The following is a description of a gene set: A metabolic process that generates a pool of NADPH by the reduction of NADP+. species: Mus musculus Mouse Gene Set: GOBP_NADPH_REGENERATION, and this is the list of marker genes: Trp53, H6pd, G6pd2, Tkt, G6pdx, Taldo1, Rbks, Pgls, Aldh1l2, Idh1, Mtor, Prps2, Mlst8, Acacb, Aldh1l1, Tigar, Rptor, Rpe, Aldob, Aco1, Pgd, Prps1, Hsd11b1, Shpk, Nnt, Rpia